Given this list of marker genes BCL11A, RHPN2 (NCBI Gene Id 85415), CD24, CLDN3, NECTIN4, EHF, C1orf210, CLDN4, LRBA, SDR42E1, APOC1, FZD6, PRSS8, LTF, DEDD2, CDH3, RIPK4, GRHL2, AP1M2, BLMH, EPHA1, GJB2, ESRP1, DSC2, THRSP, KLC3, EPPK1, ELOVL7 (NCBI Gene Id 79993), ACOT2, JUP, LSR, MYH14, ACOT1 (NCBI Gene Id 641371), OVOL1, NIPAL2, TMPRSS13, GRB7, CDH1, CLDN1, CEACAM1, PPIF, DENND2D, DDR1, CRB3, ENDOU, MARVELD2, CXADR, ST14, ESRP2, STARD10, MAP7, CYSRT1 (NCBI Gene Id 653325), CKMT1B, SPINT1, ARHGEF16, EPS8L2, TFAP2C, IL17RE, SORT1, PTPRF, EFNA3, CHDH, TJP3, EPS8L1 (EPS8 signaling adaptor L1), KDF1, ILDR1, LLGL2, MPZL2, GRHL1, CELSR2, ATP6V1C2, PATJ, HIP1R, PPFIBP2, TMEM54, C1orf56, ELMO3 (engulfment and cell motility 3), EPB41L4B, SPTBN2, TMC4 (transmembrane channel like 4), ELF5, GSDMA (gasdermin A), TMEM184A, CBLC, NRTN, PKP3, EVPL, EPCAM, STAP2, SHROOM3, IDE, DSG2, IRF6, WWC1, SLC5A9, RAB25, CALML3, MYO5B, PLEKHG6, MAL2, PLEKHH1, TMEM30B, TMPRSS2, KCNK1, FXYD3, SPINT2, CLIC3, CLDN7, CDCP1, BSPRY, ERBB3, TMEM79, KRT15, POF1B, RNF43, KIF21A, TNK1, ZNF185, FAM83H, DSP, CCDC120, EPB41L5, OCLN, here is a description of the gene set: Human breast cancer has been characterized by extensive transcriptional heterogeneity, with dominant patterns reflected in the intrinsic subtypes. Mouse models of breast cancer also have heterogeneous transcriptomes and we noted that specific histological subtypes were associated with particular subsets. We hypothesized that unique sets of genes define each tumor histological type across mouse models of breast cancer. Using mouse models that contained both gene expression data and expert pathologist classification of tumor histology on a sample by sample basis, we predicted and validated gene expression signatures for Papillary, EMT, Microacinar and other histological subtypes. These signatures predict known histological events across murine breast cancer models and identify counterparts of mouse mammary tumor types in subtypes of human breast cancer. Importantly, the EMT, Adenomyoepithelial, and Solid signatures were predictive of clinical events in human breast cancer. In addition, a pan-cancer comparison revealed that the histological signatures were active in a variety of human cancers such as lung, oral, and esophageal squamous tumors. Finally, the differentiation status and transcriptional activity implicit within these signatures was identified. These data reveal that within tumor histology groups are unique gene expression profiles of differentiation and pathway activity that stretch well beyond the transgenic initiating events and that have clear applicability to human cancers. As a result, our work provides a predictive resource and insights into possible mechanisms that govern tumor heterogeneity. from publication Hollern DP, Swiatnicki MR, Andrechek ER (PMID 29346386) Genes that that have low expression in mammary tumors of epithelial-mesenchymal transition (EMT) histology. Human Gene Set: HOLLERN_EMT_BREAST_TUMOR_DN studied in species Mus musculus